Given this list of marker genes Cd28, Prkdc, Mcm3ap, Rnf168, Mlh1, Shld2 (shieldin complex subunit 2), Ctnnbl1, Tbx21, Ercc1, Tfrc, Stat6, Bcl6, Mir181b-2, Msh2, Foxp3, Shld3, Sanbr, Cyren, Ezh2, BC037156, Ndfip1, Lig4, Swap70 (NCBI Gene Id 20947), Ighd, Tcf3, Msh3, Nsd2, Kmt5b, Nbn, Yy1, Rnf8, Nhej1, Exosc3, Pagr1a, Polm, Aicda, Polb, Mir181b-1, Icosl, Exo1, Slc15a4, Xrcc4, Msh6, Il2 (interleukin 2), Tnfsf4, Shld1 (shieldin complex subunit 1), Supt6, Ung, Pms2, Cd40lg, Atad5 (ATPase family, AAA domain containing 5), Parp3, Il4, Nfkbiz, Polq, Rif1, Mad2l2, Tgfb1, Ccr6, Cd40, Il27ra, Tnfsf13, Nuggc, Aplf, Batf, Trp53bp1, Hspd1, Ifng, Kmt5c, Exosc6, Ptprc, Hmces, Paxip1, Clcf1, Pcyt1a, Foxp1, Samhd1, here is a description of the gene set: species: Mus musculus The somatic process that results in the generation of sequence diversity of immunoglobulins. Mouse Gene Set: GOBP_SOMATIC_DIVERSIFICATION_OF_IMMUNOGLOBULINS